Given this list of marker genes GZMA, GZMH, ADORA3, LYZ, GZMB, C8B, PRF1 (NCBI Gene Id 5551), EDNRA, C5, GZMM, C7, MMD (NCBI Gene Id 23531), here is a description of the gene set: Human Gene Set: MODULE_575 studied in species Homo sapiens Complement and cAMP signaling.